The following is a description of a gene set: The chemical reactions and pathways resulting in the formation of galactolipids, any glycolipid containing one of more residues of galactose and/or N-acetylgalactosamine. species: Homo sapiens Human Gene Set: GOBP_GALACTOLIPID_BIOSYNTHETIC_PROCESS, and this is the list of marker genes: B3GALT2, GAL3ST1, UGT8, B4GALT3, FA2H, B3GALT1